The following is a description of a gene set: The process in which a transformation is induced in the geometry of a DNA double helix, resulting in a change in twist, writhe, or both, but with no change in linking number. Includes the unwinding of double-stranded DNA by helicases. species: Homo sapiens Human Gene Set: GOBP_DNA_GEOMETRIC_CHANGE, and this is the list of marker genes: HMGB1, MTERF1, WRN, HMGB3, HNRNPA2B1, DNA2, BLM, HMGB2 (NCBI Gene Id 3148)